The following is a description of a gene set: Genes predicted to be targets of miRBase v22 microRNA hsa-miR-1253 in miRDB v6.0 with MirTarget v4 prediction scores > 80 (high confidence targets). Human Gene Set: MIR1253 from publication Chen Y, Wang X (PMID 31504780) species: Homo sapiens, and this is the list of marker genes: MPZ, PIP4P2, PDE11A, DLG2, HSF2, WASF2, FBN2, ECT2, KCND1, SP1, MIDEAS, CYB561D1 (cytochrome b561 family member D1), EPB41L1, PTPRO, SNX13 (sorting nexin 13), ADGRL4, ANKH, FBXW7, EPN3, WNT5A, PPP3R1, TRIM58, TCERG1, PIM1, FCRL4, ACSL1, CFAP97, ENDOV, CSNK1G1, BICD2, FERRY3, HDHD2, SYPL2, ENPEP (glutamyl aminopeptidase), S100A7A, NLGN1, NLK, FAM47E, STAT1, FAM124B, RP9, MED13, UGT2A3, SEPTIN14, TMPRSS13, AHCYL1, CDX1, RPS6KB1, RPRD1A, TMEM178B, PIKFYVE, CD276, ARL4D, COPG2, MTCL2, TOP2A, FGF7 (fibroblast growth factor 7), NHSL1, GFRAL, CDC20B, DUSP16, ACRV1, KMT2C (lysine methyltransferase 2C), TAS2R13, CACNB4, ZBTB20, PHB1, PPM1H, CAMK1D, ARHGAP26, DTNBP1, CHFR, TAFA2, ADCY10, RBPJL, INSR, ISG20, APOOL (apolipoprotein O like), ENTPD7, ELF5, OXCT1, UPF2, RGS4, ZNF585B, TEDDM1, SNX4, ZFYVE16, SERTAD2, CTSO, TOB2, KRT6B, ATF6B, SCN7A, TOPBP1, AMOT, COL11A1, FEM1C, PLXNA2, DLG4, PTGER4, EPRS1, KLF7, TFCP2L1, PPM1N, PPP1CC, ERAP1, HTT, BHMT2, DTX3L, SOBP, OPRK1, SLC1A7, ANKRD44, IKZF2, IGSF11, MTHFSD, NOVA2, WIPF2, MITD1, PCYT1A, TXLNA, CHODL, PSEN1, DYNC1I1, MTARC1, SRL, HDGFL3, INTS9, C17orf75, SLC36A1, ENSA, FNDC5, TCF24, HYDIN, EPPIN-WFDC6, SMCO4, MICAL2, LCOR, MTERF4, RNF19A, SMKR1, VSTM4, RPL22 (NCBI Gene Id 65281), FAM131A, PSMF1 (proteasome inhibitor subunit 1), KDM7A, RAB14, RSBN1, COX11, PARP11, HLA-DPA1, ZNF330, MSX2, QKI, LUZP1, CACUL1, SPC25, GABRA4, LPP, ILDR2, PLD1, UCHL5, RBBP4, NKAIN1, RAB3C, EPOR, HSD17B12, FGF14, SPATA6, FGL1 (fibrinogen like 1)